Given this list of marker genes ACLY, ELOVL6, FDPS, SC5D (sterol-C5-desaturase, NCBI Gene Id 6309), CYP51A1, ACAT2, ZMAT4, STARD4, TM7SF2, DHCR7, LSS, SQLE, FGL1 (NCBI Gene Id 94993), SREBF2, MSMO1, AASDH, MVK, INSIG1, IDI1, SCD, FDFT1, CYP26A1, MVD, FOXC1, NSDHL, HMGCS1, LDLR, here is a description of the gene set: from publication Schmidt K, Hughes C, Chudek JA, Goodyear SR, Aspden RM, Talbot R, Gundersen TE, Blomhoff R, Henderson C, Wolf CR, Tickle C (PMID 19273610) Cytochrome P450 oxidoreductase (POR) is the obligate electron donor for all microsomal cytochrome P450 enzymes, which catalyze the metabolism of a wide spectrum of xenobiotic and endobiotic compounds. Point mutations in POR have been found recently in patients with Antley-Bixler-like syndrome, which includes limb skeletal defects. In order to study P450 function during limb and skeletal development, we deleted POR specifically in mouse limb bud mesenchyme. Forelimbs and hind limbs in conditional knockout (CKO) mice were short with thin skeletal elements and fused joints. POR deletion occurred earlier in forelimbs than in hind limbs, leading additionally to soft tissue syndactyly and loss of wrist elements and phalanges due to changes in growth, cell death, and skeletal segmentation. Transcriptional analysis of E12.5 mouse forelimb buds demonstrated the expression of P450s involved in retinoic acid, cholesterol, and arachidonic acid metabolism. Biochemical analysis of CKO limbs confirmed retinoic acid excess. In CKO limbs, expression of genes throughout the whole cholesterol biosynthetic pathway was upregulated, and cholesterol deficiency can explain most aspects of the phenotype. Thus, cellular POR-dependent cholesterol synthesis is essential during limb and skeletal development. Modulation of P450 activity could contribute to susceptibility of the embryo and developing organs to teratogenesis. Human Gene Set: SCHMIDT_POR_TARGETS_IN_LIMB_BUD_UP studied in species Mus musculus Genes up-regulated in E12.5 forelimb buds with POR knockout.